Given this list of marker genes Terf2, Ctc1, Pola2, Acd, Terf1, Pola1, Prim1, Ten1, here is a description of the gene set: electronically inferred by orthology from the curated human pathway This event has been computationally inferred from an event that has been demonstrated in another species.<p>The inference is based on the homology mapping from PANTHER. Briefly, reactions for which all involved PhysicalEntities (in input, output and catalyst) have a mapped orthologue/paralogue (for complexes at least 75% of components must have a mapping) are inferred to the other species. Reactome Pathway: Telomere C-strand synthesis initiation part of: Telomere C-strand (Lagging Strand) Synthesis studied in species Mus musculus